Given this list of marker genes Csnk2b, H4c3, H4c1, Cdh1, Cdh3, Rps27a, H2ac6, Cdh18, H3c3 (H3 clustered histone 3), H2ac19 (NCBI Gene Id 319192), Pip5k1c, Ddost, H2ac13, H2bc13 (NCBI Gene Id 319185), Ctss, H3f3a, Cdh6 (NCBI Gene Id 12563), Psma2, Psma6, Actg2, H4c6, H2ac7 (NCBI Gene Id 319165), Psmc2, Ubb, Psmd1, Rack1, H4c4 (H4 clustered histone 4), Cdc42, H2bc15, H2az2, Psmd6, Psmc6, Psmc5, Rbbp4, H2bc22, H4c14, Cdh7, Dad1, H2ac20, H2ac15, H4c8, Il6ra, Psmc4, Nectin2, Cdh8, Nectin4, Jup, Rbbp7, Dnm2, H3c10, Psma4, Psma5, Acta1, Sec11c, H4c18, H2bc1, Dnttip1, Psmb6, Actc1, Mtbp, Psma3, H2bc12, Stt3a, H2bc7, Nfkb1, H2bc8, Pcsk7, Ezh2, Psmd7, H2ac1, Spcs3, Angptl4, Psmc1, H4c17, H3c2, Cdh12, Psma1, Prkcsh, Ost4, Spcs2, Psmb5, H2ac11, H4c2, Zmym2, H2ac4, Tyk2, Psma7, H2ac8, H3c4, H4c12, Cdh15, Banp (NCBI Gene Id 53325), Psmc3, H3c6, Psmb7, Ang, Ganab, Cbll1, Cadm3 (NCBI Gene Id 94332), Cdh2, Rela, Spcs1 (NCBI Gene Id 69019), H3c8, H2bc11, H2ac10, H3c15, H2ac24, H4c9, Twist1, H2ax, H4c11, H2bc27, Pomt1, Psmb4, Psmd13, Adam19, H3c7, Cdh5, H2bc9, H2ac23, Tmem258, Psmd12, Ilf3, Fyn, H3c13, Il6, H3c1, H3c11, Ctnnb1, Kdm1a, Smarca4, H2ac22, H2bc3, Pomt2, H2ac12, here is a description of the gene set: electronically inferred by orthology from the curated human pathway part of: Cell-cell junction organization Reactome Pathway: Adherens junctions interactions species: Mus musculus This event has been computationally inferred from an event that has been demonstrated in another species.<p>The inference is based on the homology mapping from PANTHER. Briefly, reactions for which all involved PhysicalEntities (in input, output and catalyst) have a mapped orthologue/paralogue (for complexes at least 75% of components must have a mapping) are inferred to the other species.